Given this list of marker genes Acvr1, Nphp3 (NCBI Gene Id 74025), Bmpr2, Notch2, Tbx20, Cfc1, Tgfb2, Nsd2, Ank2, Gja5, Mdm2, Smo, Nkx2-5, Wnt11, Ccn1, Wnt5a, Isl1, Gata4, Tbx5, Sox4, Mdm4, Hey2, Dand5, Zfpm1, here is a description of the gene set: Mouse Gene Set: GOBP_ATRIAL_SEPTUM_DEVELOPMENT The progression of the atrial septum over time, from its initial formation to the mature structure. studied in species Mus musculus